Given this list of marker genes TRPV1, PML, P2RX1, CACNA1G, NPSR1, CACNA1H, CACNA1B (NCBI Gene Id 774), CYBA (NCBI Gene Id 1535), LIME1, MCOLN1, DMD, GP1BB, CXCL10, NOL3, MS4A1, PLCG1, PLCL2, TRDN, THY1, CXCL9, NOS1, AKAP6, FYN, TMEM38A, PLCB2, GHITM, CAPN3, METTL21C, CALCA, SLC24A1, ABL1, PRKCE, PPP3CB, TMBIM6, DHRS7C, GRIN2A, ITPR2, TRPV3, MIR93, CASQ1, BDKRB1, CAV1, CD19, CHERP, CCL21, PLCB1 (NCBI Gene Id 23236), F2, SLC8A1, TRPM1, FKBP1B, TRPC1, ITPR1, CACNA1S, GSTO1, TRPA1, IL13, P2RY6, ATP2B4, CEMIP, SLC8A3, TRPV5 (NCBI Gene Id 56302), GP1BA, CACNB3, LYN (LYN proto-oncogene, Src family tyrosine kinase), PRKACA, AKAP5, PTPRC, HTR2C, ADCYAP1R1 (NCBI Gene Id 117), HTR2A, EPO, MIR208A, PDE4D, SLC24A4, CACNA1E, PDPK1, GRIN1, TRPM2, CACNA1I, CHD7, XCL1, GP9, NGF, ITPR3, HAP1, GPER1, ATP1A2, IBTK, P2RX2, SNCA, GSTM2, GRM6, TRPV2, GRIN2B, PLCB3, ERO1A, PKD2, PLCH2, RYR3, PLCB4, CACNA1F, APLNR, FKBP1A, FASLG, ASPH, PLCG2, CCR7, SLC8A2, PRNP, TRPV6, DRD1, LCK, HRC, GP5, KCNN4, BCL2, SRI, CACNA1C, P2RX4, P2RX5, MIR133A1, HTT, CCR5, SLC24A2, F2R (coagulation factor II thrombin receptor), MIR200C, ATG5, PLN, PLA2G1B, CX3CL1, SLC8B1, CD4, CXCR3, JPH2, CALM1, RYR2, LETM1, PLCE1, PTK2B (NCBI Gene Id 5748), P2RX3, GRIN2C, GRIN2D, ITGB3, DDIT3, HTR2B, LACRT, XCR1, PPP3CA, CCL3, CALM3, CLIC2, CALM2, BAK1, P2RX7, CCL19, FGF2, PTPN6, MIR208B, TGFB1, MIR1-1, BAX, CASQ2, F2RL3, TMEM38B, PPP3CC, ANK2, PRKD1, JPH1, DIAPH1, PLCL1, CAMK2D, DRD2, FLNA, PLCH1, NALF2, PPP3R1, PPP3R2, CACNA2D1, UBASH3B, SELENON, CACNA1D, TRPC3, CXCL11, RYR1 (ryanodine receptor 1), TRPV4, CACNA1A, KCNK16, JPH3, NALF1, TPCN2, JPH4, CORO1A, NTSR1, here is a description of the gene set: A process in which a calcium ion is transported from one side of a membrane to the other into the cytosol by means of some agent such as a transporter or pore. Human Gene Set: GOBP_CALCIUM_ION_TRANSMEMBRANE_IMPORT_INTO_CYTOSOL studied in species Homo sapiens